Given this list of marker genes Tespa1, Ada, Il7r, Zfp609, Shh, Egr3, Skint1, Ihh, Vnn1, Rasgrp1, Il2rg, Adam8, here is a description of the gene set: Mouse Gene Set: GOBP_POSITIVE_REGULATION_OF_T_CELL_DIFFERENTIATION_IN_THYMUS Any process that activates or increases the frequency, rate or extent of T cell differentiation in the thymus. studied in species Mus musculus